Given this list of marker genes EMSY (NCBI Gene Id 56946), PGRMC1, POLR2J, GABRR2, IDO2, RNF19B, IL1RN, RBM7, SPARC (NCBI Gene Id 6678), CPEB2, HPGD, TFPI, NPDC1, NAB2, RAB21 (NCBI Gene Id 23011), ETF1 (eukaryotic translation termination factor 1), HILPDA, TSC22D1 (NCBI Gene Id 8848), WDR6 (NCBI Gene Id 55098), SLC38A2, ABCF3, STAMBPL1, ADH1C, APAF1, RASA2, SLC41A1, TNIP1, PRDX5, KCNJ11, CHKA, SOS2, HCAR2, FOXK1, FPR1, NCK1, PTGER4, EFNA3, ERRFI1, NFKBIE, SERPINB1, SERINC1, MSH4, ABCB10, ZDHHC20, BCL2L2, KLRG1, FOXJ3, NRAP, FGL1, KDM4C (lysine demethylase 4C), ATP5F1E, YBX2, INTS12, LARGE1, UBC, CD14, HHAT, RFFL, A2M (NCBI Gene Id 2), EIF1 (eukaryotic translation initiation factor 1), CLASP1, CDK2, MUC1, SAMSN1, NR1H3, SQSTM1, MLLT10, FKBPL, PFKM, CELA1, PRKCI, TFEC, RTN1, TAF13 (TATA-box binding protein associated factor 13), SOX2, NFKBIB (NCBI Gene Id 4793), TTYH2, ABRACL, TBC1D1, SLC22A13, KPNA3, SNCB, FOS, SUPT6H, SERPINB9, CD274, ST8SIA4, RREB1, TOP1, EML3, CD200, TLK2, ADORA2A (NCBI Gene Id 135), LRRC4, RNF41, ARMCX2, ST3GAL1 (NCBI Gene Id 6482), TLR2, TGM2, KBTBD4, SKIL, CIDEB, DRD4, BMERB1, GTF2B, CLOCK, HADH, SLC15A2, KLC1, APBB3, TIPARP, CLYBL, FBXW11, KDM1A, YJU2B, KRT84 (NCBI Gene Id 3890), PRRT1, DTNB, WDR20, RABGEF1, CPNE1, PACSIN3, SYN3, NPL, LAMTOR3, KYNU, GSTM5, IL12A, PSCA, MED21, LCP2, AGR2, COL11A1, CCNL1, TUSC3, SFRP5, UBR2, TMEM143, SMAD7, TMEM38A, SLFN12L, NTN3, RABGAP1, TBK1, DUSP8, ACP3, RNF19A, ADSS2, SLC6A4, EREG, ADHFE1, LIN9, BAALC, CHURC1, NCK2, SEC24D, BCL2L11, SFXN4, STXBP3, SLURP1, FITM1, KCTD10, KCNMB2, PGS1, SLC39A11, SF3B1, ELL2, CDC42EP3, GADD45B, RCSD1, DLST, NEAT1, CNOT7, IL15RA, ICAM4, CYP1A1, CHRNA7, SAA1, RGS2, DCBLD2, PHLDB1, MZF1, CLRN3, HK2, SPIC, PELI1, SMARCD3, SLN, IMMP2L, MTMR7, SOX15, PUM2, COCH, CD9, ZFP36, ATP12A, MTMR1, TMED4, CBX4, RYR1, here is a description of the gene set: Genes down-regulated in comparison of dendritic cells (DC) stimulated with poly(I:C) (TLR3 agonist) at 1 h versus DC cells stimulated with CpG DNA (TLR9 agonist) at 1 h. studied in species Homo sapiens from publication Amit I, Garber M, Chevrier N, Leite AP, Donner Y, Eisenhaure T, Guttman M, Grenier JK, Li W, Zuk O, Schubert LA, Birditt B, Shay T, Goren A, Zhang X, Smith Z, Deering R, McDonald RC, Cabili M, Bernstein BE, Rinn JL, Meissner A, Root DE, Hacohen N, Regev A (PMID 19729616) Human Gene Set: GSE17721_POLYIC_VS_CPG_1H_BMDC_DN mouse primary BMDCs were stimulated with tlr ligands and gene expression changes were profiled on Affymetrix arrays